The following is a description of a gene set: Human Gene Set: AIZARANI_LIVER_C23_KUPFFER_CELLS_3 studied in species Homo sapiens from publication Aizarani N, Saviano A, Sagar, Mailly L, Durand S, Herman JS, Pessaux P, Baumert TF, Grün D (PMID 31292543), and this is the list of marker genes: MYO1F, SECTM1, CTSS, PLCB2, ANXA1, CCR1, CD93, SERPINB1, NFAM1, TRPS1, FCN1, BCL6, JDP2, PTGS2, SH3BGRL3, DOK3, CPPED1, RASSF2, OAZ1, SLA (NCBI Gene Id 6503), TYMP, RAB31, PLP2, S100A10, CD37, LAPTM5, CYBB, ARRB2, CLEC4E, RHOG, SLC11A1, EMILIN2, TLR2, JARID2, PTAFR, SIRPB2, HCK, AGFG1, NCF2, LYZ, PLBD1, MPP1, MNDA, CPVL, PKM, SLC7A7, TNFAIP2 (TNF alpha induced protein 2), ITGAX (NCBI Gene Id 3687), FCER1G, PLAUR, GRN, SELL, RTN3, CDC42EP3, RIPOR2, IL1R2, TMEM127, FBLIM1, SMAP2, FTH1, VCAN, LST1, APLP2, RGS2, HCLS1, ZNF281, S100A12, WAS, PTEN, APOBEC3A, IRAK3, MEGF9, ALDOA, LILRB2, MPEG1, SAMHD1, LRRK2, SIRPB1, TYROBP, ATP6V1B2, POU2F2, CKAP4, TREM1, RN7SL368P, CD44, CD163, IL17RA, S100A11, ADA2, ATP6V0B, DDX60L, LY86, S100A9, AIF1, MACROH2A1, THBS1 (NCBI Gene Id 7057), GMFG, GRK2, VSIR, HSPA1B, LGALS1, VNN2, KLHL8, CLEC12A, ATP2B1, CREB5, RILPL2, CSF3R, RNASEK, SLC25A37, IL1B, FYB1, MAFB, MX2, S100A4, GCA, KCTD12, PREX1, LRRFIP1, PSAP, FPR1, TNFSF13B, TNFRSF1B, JAML, S100A8, LIMS1, EFHD2, PRKCB, ATP2B1-AS1, CFP, S100A6, NFKBIA, LINC02909, HK3, LILRB3, CNTRL, IGSF6, TKT, GNAI2, TSPO, SPTLC2, CCDC88A, VMP1, PTK2B, EVI2B, GAS7, SRGN, TET2, GRB2, CLEC7A, ROCK1, LTA4H, ZEB2, PCDH11Y, MACC1, LYN, ZNF471, NLRP12, FGL2, ITGB2, AHR, C5AR1, METTL21A, IRS2 (insulin receptor substrate 2), ACTB, TRIM38, CALM2, BCL2A1, PILRA, CCDC69, PTPRE, LINC01001 (NCBI Gene Id 100133161), RNF144B, CSTA, GMEB1, CXCL8, VIM, IFNGR2, CD55, NAIP, SAMSN1, KCNMB1, RNF130, CD52, CFD, ALOX5, PARVG, CD300E, TALDO1, SLC2A3, CTSB, HSPA1A, SKAP2, NAMPT, PLXDC2, DUSP6, ITGAM, FGR, SLC43A2, GLIPR2, PRKCD, SDCBP, MARCHF1, CSGALNACT2, USP15, FCGR2A, FKBP1A, PLEK (NCBI Gene Id 5341), SOD2, COTL1, EREG, AP1S2, GK, PELATON, SAT1, VSTM4, C1orf162, PHC2, BASP1, CD14, AREG